The following is a description of a gene set: Comparisons of global gene-expression profiles revealed a greater distinction between CD4+ Treg cells and CD4+ conventional (Tconv) T cells residing in abdominal (epidydimal) fat versus in more standard locations such as the spleen, thymus and LN. studied in species Homo sapiens Human Gene Set: GSE7852_THYMUS_VS_FAT_TCONV_UP from publication Feuerer M, Herrero L, Cipolletta D, Naaz A, Wong J, Nayer A, Lee J, Goldfine AB, Benoist C, Shoelson S, Mathis D (PMID 19633656) Genes up-regulated in comparison of thymus conventional T cells versus fat tissue conventional T cells., and this is the list of marker genes: SGK3, PRRG1, ABLIM1, NR2C1, DBNL, MTURN, AAGAB, FIRRM, FBXW10, OGT, TIMELESS, ZER1 (NCBI Gene Id 10444), LHX2, BCOR, PTGFRN, FAM8A1, ABHD18, ASXL1, ADA, TARBP2, ARGLU1, DYNLT1, PDZD2, CNOT6, ARMT1, TMCO6, GEMIN6, KRTAP3-3, IRGQ, CTSC, GSKIP, RNASE6, NCBP2 (nuclear cap binding protein subunit 2), NSMCE1 (NCBI Gene Id 197370), PARD6G, NUSAP1, MLLT11, TTK, BCS1L, BNIP1, MFAP3, TTC5, PPM1B, ZSCAN29, ZNF592 (zinc finger protein 592), CBX2, MED14, MCOLN3, RNF14 (NCBI Gene Id 9604), ALDH5A1, TUBE1, TMEM87B, PLD3, MAGI3, LDHB, EAF1, AP3S1, MGST2, STK24, C2orf68, SPSB1, CBX1, ZNF266, ATP8A1 (ATPase phospholipid transporting 8A1), DNAJC5, GRHPR, ARV1, SH3PXD2A, GPR18, OASL, TMEM9, NATD1, SPAST, PLK1, JMJD8, SLC35A4, MYB, AP3M1, DMTF1, UBN2, ARMCX1, ELOVL7, DLG1, MTERF1, GGA2, TBK1, RRAS2, TIMMDC1, LMF1, MED8, CCND3, CAP2, COG6, PALS2, LEF1, CELSR2, IGSF23, CACNA2D4 (calcium voltage-gated channel auxiliary subunit alpha2delta 4), PSMD11, FEN1, RAB5B, GORAB, ALDH2, PBX2, RNF170, ZFAND6, C6orf120, TDRP, ZBTB5, ERCC4, MYH6, SATB1, SLC15A1, BRMS1L, IGF2BP3, UQCC6, ATP9A, IFT70A, SLC39A14, SPDL1, IREB2, RNF145, MYOG, ITM2A, SCG5, SGO2, TET1 (tet methylcytosine dioxygenase 1), PCGF3, ZBTB18, HDHD2, SUV39H1, HARBI1, OTUB1, MSRB2, ZNF280C, THNSL1, PDHA1 (NCBI Gene Id 5160), RAD51AP1, SLC30A7, PTPRF, TNKS, CYB5R1, NEMP1, TPP1, CDK2, MTX3, POLD2, CHEK2 (NCBI Gene Id 11200), WTAP, ADCY6, GK5, EIPR1, ABRAXAS2, CEPT1, TIA1 (TIA1 cytotoxic granule associated RNA binding protein), MACO1, LGALS9B, RAD51, CENPP, ATAD5, ZNF22, SPNS1, BEND5 (NCBI Gene Id 79656), LIPT1, MIEF1, AMIGO2, ERI1, HDDC3, TNFRSF13B, RC3H1, ZNF43, UBXN11, COQ10A, ASF1A, SMIM7, GPR146, UGDH, ZNF600, MSS51, ADGRL1, PWP1, DNMT3A, SMC5, SLC26A6, CHDH (choline dehydrogenase), GALNT11, ZFYVE28, DIP2C, TPM3, C1orf131, TBL1X, STON1, LPCAT3, CNOT3 (NCBI Gene Id 9756), DGLUCY, NAPG (NSF attachment protein gamma), CCNB1IP1, ACER3, ALDH7A1, DRAM2